The following is a description of a gene set: Human Gene Set: GOCC_TERTIARY_GRANULE_LUMEN studied in species Homo sapiens Any membrane-enclosed lumen that is part of a tertiary granule., and this is the list of marker genes: ORM1, PRSS3, PTX3, HBB, CST3, YPEL5, ILF2, SPTAN1, LTA4H, PGLYRP1, IDH1, PRG3, ALDOC, CYFIP1, CRISP3, CDA, CTSS, QPCT, MMP8, GGH, CNN2, OLFM4, CTSD, CHIT1, CFP, PTPN6, CAMP, CTSH, PPBP, NIT2, FTH1, TIMP2, PGM1, ALDOA (NCBI Gene Id 226), TMT1A, DBNL, QSOX1, FLG2, CXCL1, MMP9, GSDMD, OSCAR, LTF, ARMC8, TCN1, GOLGA7, LRG1, CSTB, ASAH1, B2M, TNFAIP6, CANT1, HP, LYZ, FOLR3